Given this list of marker genes RP1, KRT77, CCN5, GSDMA, PRELP, CYSRT1, ADGRE4P, BLK, CCM2L, here is a description of the gene set: species: Mus musculus We report the application of single-molecule-based sequencing technology for high-throughput profiling of histone modifications in mammalian cells. By obtaining over four billion bases of sequence from chromatin immunoprecipitated DNA, we generated genome-wide chromatin-state maps of mouse embryonic stem cells, neural progenitor cells and embryonic fibroblasts. We find that lysine 4 and lysine 27 trimethylation effectively discriminates genes that are expressed, poised for expression, or stably repressed, and therefore reflect cell state and lineage potential. Lysine 36 trimethylation marks primary coding and non-coding transcripts, facilitating gene annotation. Trimethylation of lysine 9 and lysine 20 is detected at satellite, telomeric and active long-terminal repeats, and can spread into proximal unique sequences. Lysine 4 and lysine 9 trimethylation marks imprinting control regions. Finally, we show that chromatin state can be read in an allele-specific manner by using single nucleotide polymorphisms. This study provides a framework for the application of comprehensive chromatin profiling towards characterization of diverse mammalian cell populations. from publication Mikkelsen TS, Ku M, Jaffe DB, Issac B, Lieberman E, Giannoukos G, Alvarez P, Brockman W, Kim TK, Koche RP, Lee W, Mendenhall E, O'Donovan A, Presser A, Russ C, Xie X, Meissner A, Wernig M, Jaenisch R, Nusbaum C, Lander ES, Bernstein BE (PMID 17603471) Genes with low-CpG-density promoters (LCP) bearing histone H3 trimethylation mark at K27 in neural progenitor cells (NPC). Human Gene Set: MIKKELSEN_NPC_WITH_LCP_H3K27ME3